The following is a description of a gene set: Mouse Gene Set: GOBP_MONOATOMIC_ANION_TRANSMEMBRANE_TRANSPORT species: Mus musculus The process in which a monoatomic anion is transported across a membrane. Monatomic anions (also called simple anions) are negatively charged ions consisting of exactly one atom., and this is the list of marker genes: Apol11a, Bsnd, Slc17a8, Clcnka, Ripk1, Gabra1, Glrb, Mtor, Chrm5, Gabre, Glra3, Aqp6, Slc25a27, Ano5, Vdac3, Glra2, Best2, Slc5a5, Slc12a5, Slc26a4, Clcn2, Slc4a10, Clcn7, Casr, Slc1a3, Lrrc8a (NCBI Gene Id 279036), Gabrg1, Slc39a14 (NCBI Gene Id 213053), Slc12a3, Clic5, Slc1a4, Gabra2, Slc25a14, Slc26a11, Slc1a7, Ano1, Clcn6, Gabra5, Pcyox1, Panx1, Slc19a1, Clcn3, Cftr, Slc26a1, Vdac2, Slc6a2 (NCBI Gene Id 20538), Gabrb1, Gabra6, Cldn17, Slc4a3, Ttyh2, Ano10, Slc4a7, Clcnkb, Slc17a7, Gabra3, Slc5a6, Slc4a8, Slc12a2, Lrrc8d, Slc6a1, Clcc1 (NCBI Gene Id 229725), Gabrq, Ano3, Gopc, Slc12a8, Slc26a8, Slc26a9, Slc26a2, Clic1, Tcaf1, Slc26a3, Slc26a5, Gabrg3, Slc4a5, Nmur2, Slc1a1, Slc12a7 (NCBI Gene Id 52539), Pacc1, Gabra4, Slc26a7, Clca1, Ano7, Ano9, Ano8, Ano4, Gabrr2, Vdac1, Ttyh1, Gabrd, Gabrb2, Slc13a1, Gabrr3, Clic4, Cldn4, Slc4a1, Slc26a6, Lrrc8c, Slc12a6, Best3, Slc4a9, Clcn5, Oca2, Clca2, Ano2, Abcc3, Slc1a2, Clic3, Slc4a4, Mcoln3, Clca3a1, Slc12a4, Slc4a2, Tmc4, Mcoln1, Kcnk2, Ucp2, Gabrb3, Slc12a9, Clcn1, Best1, Ttyh3, Gpr89, Clcn4, Slco1a8, Glra1, Glra4, Gabrp, Slc17a6, Clic6 (chloride intracellular channel 6), Ano6, Slc26a10, Lrrc8b, Clca4a, Gabrr1, Mfsd8 (major facilitator superfamily domain containing 8), Abcb1a, Kcnk1, Abcb1b, Lrrc8e, Gabrg2, Slc12a1